Given this list of marker genes LAMTOR5, GNB5, FNIP2, LAMTOR1, FLCN, SLC38A9, LAMTOR2, RRAGC, LAMTOR4, RRAGA, LAMTOR3, here is a description of the gene set: A protein complex which is capable of GTPase activator activity. Human Gene Set: GOCC_GTPASE_ACTIVATOR_COMPLEX species: Homo sapiens